Given this list of marker genes DPYSL2, CRMP1, DPYS, DPYSL5, DPYSL4, DPYSL3, here is a description of the gene set: Human Gene Set: GOMF_DIHYDROPYRIMIDINASE_ACTIVITY species: Homo sapiens Catalysis of the reaction: 5,6-dihydrouracil + H2O = 3-ureidopropionate.